The following is a description of a gene set: Mouse Gene Set: GOMF_NUCLEOSIDE_TRIPHOSPHATASE_REGULATOR_ACTIVITY Binds to and modulates the activity of an NTPase. species: Mus musculus, and this is the list of marker genes: Evi5l, Rap1gds1, Arhgef28, Vav2, Rab3ip, Rapgef2, Sipa1, Gpsm3, Sergef, Akap13, Ect2, Pelo (pelota mRNA surveillance and ribosome rescue factor), Tbc1d22a, Ric8b, Sgsm1, Sh3bp1, Ophn1, Fgd1, Sgsm2, Arhgap26, Mtss2, Farp2 (NCBI Gene Id 98372), Lamtor5, Sirpa, Dennd2a, Dgki, Chn1, Gnaq, Rgs8, Tbc1d30, Rabgap1l, Tbc1d9b, Rap1gap2, Rgs11, Rab3gap1, Arhgap30, Arhgap20, Ralgapa2 (Ral GTPase activating protein, alpha subunit 2 (catalytic)), Eif2b5, Arhgap29, Abr, Eif5, Nprl3, Tagap, Arhgap15, Bcr, Arfgap2, Arrb1, Fgd2, Cdc42ep2, Tbc1d1, Rabgap1, Tbc1d9, Tbc1d17, Arap2, Gdi1, 1700006A11Rik, Als2cl, Srgap3, Rab3gap2, Arhgap21, Wdr41, Gopc, Tbc1d8b, Deptor, Fgd3, Gdpgp1 (GDP-D-glucose phosphorylase 1), Asap2, Plekhg6, Elmod2, Agap2 (ArfGAP with GTPase domain, ankyrin repeat and PH domain 2), Dennd5a, Ralbp1, Adap2, Git1, Tbc1d2, Arl2bp, Tbc1d5, Arhgef11, Lamtor4, Dock3, Chm, Smap2, Arhgap22, Sipa1l1, Dennd11, Cyth2, Eps8l3, Arfgap1, Agfg1, Tbc1d24, Plcb1, Arhgap1, Dock2, Rasgrf2, Agap1, Myo9a, Jun, Arhgap28, Syde2, Llgl2 (LLGL2 scribble cell polarity complex component), Rin1, Hps4, Dock7, Dnmbp, Sh3bp5, Rgs20, Rapgef3, Pcp2, Ranbp1, Spata13, Pde6d, Psd4, Ralgps1, Plcg1, Git2, Sbf1, Nckap1l, Rgs12, Dennd2d (NCBI Gene Id 99640), Thg1l, Dock10, Gbp2, Farp1, Ankrd27, Arhgap9, Tbc1d16, Itsn1, Frmd7, Smcr8, Ccdc88a, Arhgap45, Rasa2, Dis3, Rin2, Plekhg2, Arhgap35, Arhgef38, Arhgef15, Arfgef2, Cyth1, Lamtor3, Rgp1, Chn2, Rabep1, Wnt11, Sec23b, Rgs14, Gpsm1, Arhgap44, Sec61b, Rapgef5, Rasgrp4, Rgs5, Rab3il1, Gm1527, Rpgr, Rasa3, Iqgap1, Arhgap25, Lamtor2, Tbck, Rabif, Asap1, Fgd6, Lars1, Arhgap39, Arhgef33, Arhgef25, Fgd5, Dennd4b, Rcc2, Arap3, Arap1, Eef1d, Dnaja3, Ccdc88c, Rasal1, Tbc1d20 (TBC1 domain family, member 20), Pgam5, Rasgrp1, Syngap1, Arhgap4, Arhgef18, Mon1a, Sh2d3c, Arhgef4, Ralgps2, Tiam2, Arhgef10, Plekhg3, Arhgap19, Depdc1b, Dennd1a, Iqsec3, Ric8a, Plce1 (NCBI Gene Id 74055), Krit1, Rp2, Arhgef3, Arhgef12 (NCBI Gene Id 69632), Tbc1d7, Dennd3, Arhgap10, Dennd1c, Arhgap40, Elmod3, Arhgap33, Eif2b3 (NCBI Gene Id 68862), Arhgap17, Sesn2, Dab2ip, Rasal3, Vav3, Rgs10 (NCBI Gene Id 67865), Asap3, Arhgap6, Rabgef1, Mcf2l, Chml, Dennd10, Sos1, Stxbp5l, Dlc1, Adap1, Ngef, Net1, Ric1, Itsn2, Sbf2, Tbc1d15 (TBC1 domain family, member 15), Chrm4, Adgrb3, Arhgap18, Ccz1, Garnl3, Dennd5b, Gdi2, Acap1, Arfgef1 (ADP ribosylation factor guanine nucleotide exchange factor 1), Rap1gap, Depdc5, Fgd4, Gbp5, Rgs16, Fam13b, Tbc1d4, Rap1a, Tbc1d10c, Rapgef4, Sipa1l3, Agfg2, Nucb2, Srgap2, Itgb1bp1, Rasgrp2, Preb, Fbxo8, Arhgef17, Rgl2, Stxbp5, Depdc1a, Psd2, Sec23a, Rcc1, Obscn, Vav1, Prex2, Syde1, Arhgap12, Iqgap3, Arhgef16, Gipc1, Dock5, Gmip, Arhgap31 (NCBI Gene Id 80655), Rangap1, Arhgap11a, Lamtor1, Rabep2, Cpeb2, Psd3, Ngb, Gbf1 (golgi-specific brefeldin A-resistance factor 1), Tbc1d10b, Dennd6b, Tbc1d25 (TBC1 domain family, member 25), Sgsm3, Arfgap3, Acap2 (ArfGAP with coiled-coil, ankyrin repeat and PH domains 2), Eps8l1, Nf1, Arhgef1, Llgl1, Iqsec1, Eps8l2, Madd, Slit2, Kndc1, Rasgrf1, Tbc1d8, Prex1, Rinl, Rtkn, Arhgap24, Prr5, Rgs9, Arhgef40, Arhgap8, Rasgef1b, Myo9b, Hps1, Ranbp10, Sh3bp5l, Rangrf, Flcn, Dock1, Eif2b4, Gpsm2 (NCBI Gene Id 76123), Rasgrp3, Rgs17, Ralgapa1, Rasgef1a, Eif2b1, Arhgap23, C9orf72, Dock9, Tbc1d21, Arhgef10l, Rapgef1, Grtp1, Dock11, Dennd2b, Thy1, Als2, Mycbp2 (MYC binding protein 2, E3 ubiquitin protein ligase), Arhgap36, Dock6, Acap3, Sh3bp4, Dennd4c, Arfgef3, Psd, Tbcd, Rasa1, Dennd2c, Tiam1, Arhgap42, Tbc1d14, Rgs7, Dennd1b, Arhgdig, Mcf2, Rcc1l, Tbc1d22b, Ralgds, Arhgdib, Ralgapb, Cyth3, Tbc1d2b, Rapgef6, Sipa1l2, Gapvd1, Rgs1, Arhgef39, Tbc1d10a, Tbc1d12, Rgl1, Dock4, Ranbp2, Nprl2, Rgs4, Gnb5, Elmod1, Arhgap27, Egf, Slc38a9, Iqgap2, Dennd4a (NCBI Gene Id 319526), Elmo1, Bcar3, Arhgap5, Usp6nl, Sos2, Dennd6a, Plcd4, Gripap1, Tsc2, Arhgef5, Eef1b2, Htr2b, Vps9d1, Lrrk2, Rgs2, Rapgefl1, Rasgef1c, Nrp1, Arhgdia (Rho GDP dissociation inhibitor alpha), Arhgef6, Smap1, Dock8, Arhgef2, Stard13, Plekhg1, Arhgap32, Agap3, Tbc1d13, Evi5, Racgap1, Eif2b2, Nucb1, Rgs18, Rin3, Arhgef7, Hmgcr, Rasa4, Ocrl, Grb2, Trio, Arhgef37, Iqsec2, Rgs6, Stard8, Arhgef9, Cavin4, Arhgef19, Kalrn, Rgs3, Rgl3, Srgap1, Tns3, Plekhg5, Cyth4